Given this list of marker genes Pde5a, Scn11a, Ido1, Abcc1, Ccl11, Camp (cathelicidin antimicrobial peptide), Gm5849, Cx3cr1, Cebpb, Lta, Ahcy, Nfkbiz (NCBI Gene Id 80859), Vnn1, Tnf, S100a9, Tnfaip3, Il4, Unc13d, Gja1 (gap junction protein, alpha 1), Ccl2, Foxp3, Adora2b, Cyp19a1, Il10, Trav7-2, Ahcyl, here is a description of the gene set: Inflammation of prolonged duration (weeks or months) in which active inflammation, tissue destruction, and attempts at repair are proceeding simultaneously. Although it may follow acute inflammation, chronic inflammation frequently begins insidiously, as a low-grade, smoldering, often asymptomatic response. studied in species Mus musculus Mouse Gene Set: GOBP_CHRONIC_INFLAMMATORY_RESPONSE